The following is a description of a gene set: Human Gene Set: chr1p12 species: Homo sapiens, and this is the list of marker genes: PHGDH, HAO2-IT1, HSD3BP2, RPS3AP12, TENT5C-DT, HAO2, WARS2-AS1, MAN1A2, RNA5SP56, GAPDHP27, GAPDHP32, HMGCS2, HSD3BP1, HSD3BP4, LINC01780, ENSG00000273406, VTCN1 (NCBI Gene Id 79679), SPAG17, HSD3BP3, RNU6-465P, ADAM30, RBMX2P3, GDAP2, VDAC2P3, GAPDHP74, LINC01525, TENT5C, WARS2, TBX15, HSD3B1, ZNF697, RNU1-75P, ENSG00000212266, HSD3B2, NBPF7P, RPL6P2, GAPDHP23, PFN1P9, PNRC2P1, REG4, ENSG00000287980, ENSG00000273727, NOTCH2, HSD3BP5, LINC00622, WDR3, GAPDHP33, WARS2-IT1, GAPDHP58, NOTCH2P1, SEC22B, VPS25P1, PSMC1P12